Given this list of marker genes Elovl3, Abcd1, Fads1, Acsl1, Elovl5, Fads2, Elovl1, Elovl2, here is a description of the gene set: species: Mus musculus Mouse Gene Set: REACTOME_LINOLEIC_ACID_LA_METABOLISM Linoleic acid (LA) metabolism